Given this list of marker genes MIA2, GAPDH, BAD, TUBB, CORO7, CDK1, BAK1, EMC2, MT1F, RSU1, TAX1BP1, ALDOA, ANP32E, GPI, RCN1 (reticulocalbin 1), ENO3, PSAT1, RPL3, SLC25A1, SASH3, PDK3, SWI5, AK4, HMGCS1, HIKESHI, NDUFV3, ADPRM, PLAC8, ANXA4, SLC44A2 (NCBI Gene Id 57368), STAT5A, HIGD1A, BNIP3L, OSTF1, PPIA, FKBP3, IFITM3, ESYT1, ENO1, SSB, BCL2, IFITM2, here is a description of the gene set: DNA microarrays are powerful tools for the analysis of gene expression on a genomic scale. The importance of individual regulatory events for the process under study can however not be deduced unequivocally without additional experiments. We devised a strategy to identify central regulators of cancer drug responses by combining the results of microarray experiments with efficient methods for phenotypic testing of candidate genes. We exposed murine FL5.12 pro-B cells to cisplatin, camptothecin, methotrexate or paclitaxel, respectively and analysed the patterns of gene expression with cDNA microarrays. Drug-specific regulatory events as well as intersections between different apoptotic pathways, including previously studied responses to staurosporine and interleukin-3 (IL-3) deprivation, were identified. Genes shared by at least three pathways were chosen for further analysis. Ectopic expression of three such genes, TEAP, GP49B, and Lipin1 was found to have an anti-proliferative effect on pro-B cells. Interestingly, we identified hemoglobin alpha as a strong pro-apoptotic regulator. While hemoglobin-expressing cells were growing normally in the presence of IL-3, they displayed accelerated apoptosis with similar kinetics as Bax overexpressing cells upon IL-3 removal. The pro-apoptotic effect of hemoglobin was suppressed by Bcl-2 and was characterized by enhanced stimulation of caspase activity. Genes specifically down-regulated in FL5.12 cells (pro-B lymphocyte) by camptothecin. species: Mus musculus from publication Brachat A, Pierrat B, Xynos A, Brecht K, Simonen M, Brüngger A, Heim J (PMID 12447701) Human Gene Set: BRACHAT_RESPONSE_TO_CAMPTOTHECIN_DN